The following is a description of a gene set: species: Mus musculus Mouse Gene Set: GOBP_DECIDUALIZATION The cellular and vascular changes occurring in the endometrium of the pregnant uterus just after the onset of blastocyst implantation. This process involves the proliferation and differentiation of the fibroblast-like endometrial stromal cells into large, polyploid decidual cells that eventually form the maternal component of the placenta., and this is the list of marker genes: Epor, Junb, Cyp27b1, Ptgis, Ctsl, Mapk3, Pla2g4a, Parp1, Stc1, Parp2, Bsg, Ghsr, Ghrl, Vdr, Ndrg3, Gjb2, Cited2, Ctsb, Ptn, Dedd, Tppp3, Cdh1, Dcaf13 (NCBI Gene Id 223499), Kiss1, Tcf23, Ndp, Stc2, Ptgs2, Mapk1, Lif, Gja1, Il11ra1, Ppard, Ash1l